Given this list of marker genes TUBB (NCBI Gene Id 95295), TRAP1, CHCHD5, PANK2, TIMM8A, PTGES, TIMM10B, BCHE, COX4I2, TIMM8B, MICU3, CHCHD2, OMA1, TIMM10, TIMM9, NDUFS1, COX19, CDC25C, COA7, TIMM23, CMC4, CHCHD10, GATM, MICU1, AKT1, FGR, CYCS, HSD3B1, CACYBP, CPT1B, FKBP10, TIMM13 (translocase of inner mitochondrial membrane 13), NLN, MYOC, NME4, AIFM1, ARL2BP, CIAPIN1, COX6C, RNASET2, PARK7, SUOX, PNPT1, CPOX, NDUFS5, CCAR1, OPA1, IMMT, PPOX, MIX23, COA6 (NCBI Gene Id 388753), STAR (NCBI Gene Id 6770), STOML2, NBR1, ALPL, NDUFB7, CLPB, PLAAT1, AGK, CEP89, COX4I1, HTRA2, PRELID2, HSD3B2, ARL2, SORL1, THOP1, DIABLO, CD2AP, HAX1, TIMM29, THEM4, NDUFA8, TIMM21, ALOX5, COX17, COA4, SIRT5, TRIAP1, CHCHD7 (coiled-coil-helix-coiled-coil-helix domain containing 7), REXO2, APP, FBXL4, PRELID3B, SOD1, PRELID3A, COX5A, BLOC1S1, CHCHD4, AK2, PRELID1, SDHAF3, TAFAZZIN, PINK1, STMP1, GFER, IGF2R, UQCC2 (NCBI Gene Id 84300), GOLPH3 (golgi phosphoprotein 3), MICU2, here is a description of the gene set: The region between the inner and outer lipid bilayers of an organelle envelope. studied in species Homo sapiens Human Gene Set: GOCC_ORGANELLE_ENVELOPE_LUMEN